The following is a description of a gene set: Any process that modulates the frequency, rate or extent of sperm capacitation. Human Gene Set: GOBP_REGULATION_OF_SPERM_CAPACITATION studied in species Homo sapiens, and this is the list of marker genes: TCP11X1, TMPRSS12, TCP11, PAEP, TCP11X2, ADAM7